The following is a description of a gene set: Mouse Gene Set: GOBP_MRNA_TRANSCRIPTION The cellular synthesis of messenger RNA (mRNA) from a DNA template. species: Mus musculus, and this is the list of marker genes: Ap3b1, Ncbp1, Taf7, Taf11, Taf9, Stat3, Foxe3, Trp53, Taf8, Epas1, Tfcp2, Zbtb1, Taf10 (NCBI Gene Id 24075), Nr1h2, Hipk3, Ereg, Med1, Ncbp3, Taf13, Atf2, Taf1, Taf12, Vdr, Taf5, Sp1, Taf4, Enpp1, Pparg, S100a10, Creb1, Flna, Ddx5, Taf6, Ncoa2, Irf3, Rara, Zic3, Ncbp2, Atf4, Srebf1, Nfkbiz, Hltf (helicase-like transcription factor), Tbp, Thra, Rxra, Taf2, Anxa2, Taf4b, Nr1h3 (nuclear receptor subfamily 1, group H, member 3), Ncoa1, C5ar1, Taf3, Thrb, Rxrb